The following is a description of a gene set: Neuronal activity regulates the development and maturation of excitatory and inhibitory synapses in the mammalian brain. Several recent studies have identified signalling networks within neurons that control excitatory synapse development. However, less is known about the molecular mechanisms that regulate the activity-dependent development of GABA (gamma-aminobutyric acid)-releasing inhibitory synapses. Here we report the identification of a transcription factor, Npas4, that plays a role in the development of inhibitory synapses by regulating the expression of activity-dependent genes, which in turn control the number of GABA-releasing synapses that form on excitatory neurons. These findings demonstrate that the activity-dependent gene program regulates inhibitory synapse development, and suggest a new role for this program in controlling the homeostatic balance between synaptic excitation and inhibition. from publication Lin Y, Bloodgood BL, Hauser JL, Lapan AD, Koon AC, Kim TK, Hu LS, Malik AN, Greenberg ME (PMID 18815592) Human Gene Set: LIN_NPAS4_TARGETS_DN studied in species Mus musculus Genes down-regulated in neurons after NPAS4 knockdown by RNAi., and this is the list of marker genes: ARL5B, KRTAP4-6, EGR4, KLF9, HOMER1, EGR1, MIR670HG, ITPRIP, ITPKA, ARC, SORCS3, ELAVL4, TMEM86A, NPTX2, GUK1, TRMT10B, RGS4, NUP58, MLIP, KCNA1, SKP2, WDR77 (WD repeat domain 77), SV2B, SERTAD1, MIR9-2HG, HYCC2, HSD11B1, SLC12A3, OSGIN2, KIF18A, OPN3, GALNT18, IER5, GLCE, DCTN6, LMO2, EGR3, TLCD4, GADD45G, WIPF3, GPR4, KCNIP2, ZNF275, PXDN, EGR2, CRTAC1, IER2, TMTC4, YBX3, NPTX1 (neuronal pentraxin 1), DDI2, VGF, FAM210B, GPR22, KCNA4 (NCBI Gene Id 3740), HPCA, ETV3, SHISA2, SEPTIN8, FAM131A, RAB40B, TESC, ERRFI1, DICER1, FHL2, SLC4A7, ARPP21, CPNE7, BDNF, C17orf99, CRHBP (NCBI Gene Id 1393)